The following is a description of a gene set: Any process that modulates the rate, frequency or extent of stress granule assembly, the aggregation, arrangement and bonding together of proteins and RNA molecules to form a stress granule. Mouse Gene Set: GOBP_REGULATION_OF_STRESS_GRANULE_ASSEMBLY studied in species Mus musculus, and this is the list of marker genes: Prkaa2, Caprin1 (NCBI Gene Id 99144), G3bp1, Usp10, Becn1, Hsf1, Ubap2l, Styxl1, Prkaa1, Atg5 (autophagy related 5), G3bp2 (NCBI Gene Id 319444), Hif1a